Given this list of marker genes SUCLG2, HFE, RPL10, GSK3A, FAM120A, TMEM63A, CA5BP1, PACSIN3, BCL2L10, MED27, here is a description of the gene set: Human Gene Set: KIM_RESPONSE_TO_TSA_AND_DECITABINE_DN studied in species Homo sapiens Genes down-regulated in glioma cell lines treated with both decitabine and TSA. Malignant glioma is the most common central nervous system tumor of adults and is associated with a significant degree of morbidity and mortality. Gliomas are highly invasive and respond poorly to conventional treatments. Gliomas, like other tumor types, arise from a complex and poorly understood sequence of genetic and epigenetic alterations. Epigenetic alterations leading to gene silencing, in the form of aberrant CpG island promoter hypermethylation and histone deacetylation, have not been thoroughly investigated in brain tumors, and elucidating such changes is likely to enhance our understanding of their etiology and provide new treatment options. We used a combined approach of pharmacologic inhibition of DNA methylation and histone deacetylation, coupled with expression microarrays, to identify novel targets of epigenetic silencing in glioma cell lines. From this analysis, we identified >genes up-regulated by 5-aza-2'-deoxycytidine and trichostatin A treatment. Further characterization of 10 of these genes, including the putative metastasis suppressor CST6, the apoptosis-inducer BIK, and TSPYL5, whose function is unknown, revealed that they are frequent targets of epigenetic silencing in glioma cell lines and primary tumors and suppress glioma cell growth in culture. Furthermore, we show that other members of the TSPYL gene family are epigenetically silenced in gliomas and dissect the contribution of individual DNA methyltransferases to the aberrant promoter hypermethylation events. These studies, therefore, lay the foundation for a comprehensive understanding of the full extent of epigenetic changes in gliomas and how they may be exploited for therapeutic purposes. from publication Kim TY, Zhong S, Fields CR, Kim JH, Robertson KD (PMID 16885346)